The following is a description of a gene set: Human Gene Set: HP_ABNORMALITY_OF_THE_COAGULATION_CASCADE An abnormality of the coagulation cascade, which is comprised of the contact activation pathway (also known as the intrinsic pathway) and the tissue factor pathway (also known as the extrinsic pathway) as well as cofactors and regulators. species: Homo sapiens Abnormality of the coagulation cascade, and this is the list of marker genes: AMACR, ATP6V1E1, SPTA1, PLOD3, ALDOB (NCBI Gene Id 229), GNA14, VKORC1, STAT3, FGA, PLG, SLC7A7, BCOR, NABP1, HLA-DQA1, ALG12, F9, PET100, HAVCR2, ITGA2B, KNG1, ITGB3, GFI1B (NCBI Gene Id 8328), AHCY, SERAC1, SOS2, ATP6V1A, CACNA1S, IKZF5, IRF2BP2, GP9, SLC25A13, NBEAL2, TRMU, GPR35, AKR1D1, LARS1, P4HA2, CYP7B1, COG4, TRIP13, PSMB9, COX16, AGA, DIS3L2 (NCBI Gene Id 282696), F7, HSD3B7, PTPN11 (NCBI Gene Id 84990), FOXP2, FAH, ITGB2, PGM1, DPAGT1 (NCBI Gene Id 1799), COG2 (component of oligomeric golgi complex 2), HLA-DQB1, PML, MTTP, GPC3, PMM2, EFL1, LYST, GP1BB, SSR4, SERPINE1, FLNA, PROS1, FIP1L1, OSTM1, ZBTB16, EPB42, PTPN22, ALG6, UNC13D, ACAD9, REST, SEMA4D, MPDU1, HRG, F11, ANK1, THBS2, RARA, CFI (complement factor I), DDOST, ALG2, GP6, NR1H4, SRD5A3, F13B, F8, HMGCL, HELLPAR, SLC30A10, PRKAR1A, PROC, MICOS13 (NCBI Gene Id 125988), NLRC4, CLPB, DPM1, NGLY1, CD46 (NCBI Gene Id 4272), RINT1, ALG8, LMAN1 (NCBI Gene Id 3998), TRIM28, ANO6, MPV17, PRF1 (NCBI Gene Id 5551), TCF4, VWF, B4GALT1, GGCX, TNFRSF9, ADK, SLC37A4, ATP6V0A2, STX11 (syntaxin 11), MPI, STXBP2, COG8, XIAP, H19, STAT5B, NPM1, BRCA2, F13A1, MGAT2, MEFV, EPHB2, MCM10, SLC19A1, SOS1, SLC25A15, F2, HLA-B, F12, DPM2, HSD17B10, GNE (glucosamine (UDP-N-acetyl)-2-epimerase/N-acetylmannosamine kinase), MCFD2, MAP2K1, WT1, HADH, FGG, GP1BA, MST1, RYR1, F10, RFT1, STX5, F5, HLA-DRB1, FGB, TBL1XR1, NUMA1, SLC4A1, SPTB, LZTR1, BRAF, CFH, POU6F2, SERPINC1, NBAS, ALG9, OTC